The following is a description of a gene set: Ca2+ entry, Store-operated Ca2+ channel. Pathway ID: N01643. Pathway type: Reference. Pathway class: nt06528 Calcium signaling. Pathway Definition from KEGG: Ca2+(er/sr) -| STIM -> ORAI -> Ca2+(cyto) studied in species Homo sapiens Human Gene Set: KEGG_MEDICUS_REFERENCE_CA2_ENTRY_STORE_OPERATED_CA2_CHANNEL, and this is the list of marker genes: STIM1, ORAI3, STIM2, ORAI2, ORAI1